The following is a description of a gene set: Human Gene Set: HP_GLANULAR_HYPOSPADIAS Glanular hypospadias species: Homo sapiens A type of hypospadias in which the urethral meatus is located at the head of the penis, but not all the way at the tip., and this is the list of marker genes: MTM1, SLC31A1, MKKS, MAMLD1, MYMK, SRCAP, MYMX, HOXA13